Given this list of marker genes Setdb2, Mecom, Setdb1, Prdm16, Ash1l, here is a description of the gene set: Mouse Gene Set: GOMF_HISTONE_H3K9_MONOMETHYLTRANSFERASE_ACTIVITY studied in species Mus musculus Catalysis of the reaction: L-lysyl9- + S-adenosyl-L-methionine = H+ + N6-methyl-L-lysyl9- + S-adenosyl-L-homocysteine. This reaction is the addition of a methyl group to the unmethylated lysine residue at position 9 of histone H3, producing histone H3K9me.